Given this list of marker genes SGF29, CTCFL, H1-5, MACROH2A2 (macroH2A.2 histone), NIPBL, MACROH2A1, WBP2, LRWD1, RUVBL2, here is a description of the gene set: species: Homo sapiens The directed movement of a protein to a part of a chromosome that is organized into chromatin. Human Gene Set: GOBP_ESTABLISHMENT_OF_PROTEIN_LOCALIZATION_TO_CHROMATIN